The following is a description of a gene set: Any process that modulates the frequency, rate or extent of retrograde transport, endosome to Golgi. Human Gene Set: GOBP_REGULATION_OF_RETROGRADE_TRANSPORT_ENDOSOME_TO_GOLGI studied in species Homo sapiens, and this is the list of marker genes: LRRK2, RAB29, PRKN, ARFIP1, USP7, EIPR1, ATP9A